Given this list of marker genes DNAJC11, SAMM50, MTX2, MTX3, CHCHD6, MTX1, APOOL, HSPA9, APOO, CHCHD3, MICOS13, IMMT, MICOS10 (NCBI Gene Id 440574, mitochondrial contact site and cristae organizing system subunit 10), here is a description of the gene set: Human Gene Set: GOCC_MIB_COMPLEX studied in species Homo sapiens A mitochondrial intermembrane space bridging complex consisting of components of the MICOS complex in the inner mitochondrial membrane, the SAM complex in the outer membrane, a conserved DNAJ protein (human DNAJC11) and Metaxin 1.